Given this list of marker genes Foxg1, Nkx2-2, Wnt1, Prrx1 (paired related homeobox 1), Atoh1, Cdc42, Lbx1, Prox1, Fezf2, Ctnnb1, Otx2, here is a description of the gene set: The process in which a cell becomes capable of differentiating autonomously into a neuron regardless of its environment; upon determination, the cell fate cannot be reversed. Mouse Gene Set: GOBP_NEURON_FATE_DETERMINATION species: Mus musculus